Given this list of marker genes XRCC2, TMEM51, ZDHHC2, PSMB9, SYN2, SLC22A16, VIP, KCNF1, TM4SF1 (NCBI Gene Id 9004), AIF1L, DENND4A (NCBI Gene Id 10260), PCOLCE, MOV10L1, CRMP1, NXPE4, USH2A, CTTNBP2NL, TEAD1, HERC3, FOXN3, RNF169, TMEM192, SEMA6C, ADAMTS15, FBLN1, FGF12, GAREM2, KRTCAP3, PHACTR4, CDC20B, DNAAF1, AVPR1A, LRRC75A, KIF5C, FUT7, GTPBP8, CER1, CNN3, RAP1A, PRR5L, CPNE3, RHBDF1, IL17RE, IFRD1, ANXA8, FGA, PSPN, SLC25A4, VWA3A, TNFRSF17 (TNF receptor superfamily member 17), COL26A1, DUSP4, PDE11A, HSPA12A, SLCO5A1, DOCK6, RHOF, PDE6G, FKBP14, GPR162, SLC4A4, TTC34, NINJ1, NSUN7 (NCBI Gene Id 79730), EXTL3, AIM2, MMP14, CD40, STX1A, TBC1D4, C7orf50, TINAGL1, NKX2-1, UPK2, PANK2, TTLL6, C2, BMPR2, WDFY4, NUMBL, TSPAN2, C1QTNF9, PKIB, KCNAB1, TRIM9, FOXK1, ZDHHC12, ARL4A, PGM2L1 (phosphoglucomutase 2 like 1), EIF5A2, RNF24, OSBPL6, PNLIPRP2, PRG4, ESRP1, CCL7, LRCH4, JAM3, EXOSC5, KRT27, SLC44A3, LCE3B, ACVR1C, CCNA1, UGT2A3, SKIL, GCNT2, ZBTB18, ELN, FA2H, CCR6, IFITM5, MFNG, MYH9, DUSP14, KCNJ9, LYSMD3, SLC4A11, PACSIN1, CREB3L3, UBE2E1, ZNF334, PRSS8, FBXO41, C1orf56, MMP17, MYL2, SEMA6D, TTLL13, SELENOV, SORT1, SAA1, TAMALIN, NKX1-2, TEAD4, C2CD2, MICAL2, SFI1, PDZRN4, CPLX2, EPHA4, SLC25A42, SEC14L5 (SEC14 like lipid binding 5), CCDC184, FAM227B, PMEPA1, NIPAL2, DNAJB8, SPATA25, ELF4, NDRG2, FBXO42, MET, PDZK1IP1, REXO2, SLC7A14, KIF1A, SPINK8, MYO1E (NCBI Gene Id 4643), PLA1A (phospholipase A1 member A), KRTAP17-1, FGR, MAP7D2, BPIFA3, SCN2A, FBLN2, VPS37D, CEP68, OTOP2, DYNC2I1, SLC22A2, AP1S2, GMFB, RNF123, CPED1, SPDYE18, KLF10, CBLN1, WWC2, ALDOB, ANKRD6, CD86, BRINP3, ALOX15, MGAT3, ALDH18A1, VXN, CYP4F2, STEAP4, SCD, ELF3, SH3BGRL2, ATP2B3, ARPC5L, TNFSF11, RGL1, FEV, IRX1 (iroquois homeobox 1), DENND2B, DUSP18, here is a description of the gene set: species: Homo sapiens Bone marrow-derived mast cells were differentiated over 4-6 weeks using bone marrow from Pac-1+/+ and Pac1-/- littermate mice. Cell purity was 99% c-kit and Fc epsilon receptor positive as assessed by flow cytometry. Cells were stimulated by Fc epsilon receptor crosslinking using IgE-DNP/HSA for sensitization for 18 hours and DNP-HSA antigen for crosslinking for 2 hours. Gene transcript abundance was determined and scaled to 150 using alogorithms in MicroArray Analysis Suite Software 5.0 (Affymetrix). Genes up-regulated in bone marrow-derived mast cells: wildtype versus ADCYAP1R1 knockout. Human Gene Set: GSE3994_WT_VS_PAC1_KO_ACTIVATED_MAST_CELL_UP from publication Jeffrey KL, Brummer T, Rolph MS, Liu SM, Callejas NA, Grumont RJ, Gillieron C, Mackay F, Grey S, Camps M, Rommel C, Gerondakis SD, Mackay CR (PMID 16474395)